The following is a description of a gene set: Mouse Gene Set: TABULA_MURIS_SENIS_LIVER_NK_CELL_AGEING from publication Tabula Muris Consortium (PMID 32669714) studied in species Mus musculus, and this is the list of marker genes: Rpl17, Ptbp3, Neurl3, Rpl22l1, Pafah1b1, Rpl3, Odc1, Rpl27a, Rdx, Akap13, Pkp3, Ccl5, Plekha2, Erdr1, Rps20, Surf1, Gzmb, Ddx21, Slc25a4, Vmp1, Psma2, Cdv3, Taf1d, Fyn, Eif3c, Hspa5, Serpina3g (serine (or cysteine) peptidase inhibitor, clade A, member 3G), Atf4, Dnajb1, Irf2, Use1, Ly6a, Rbm39, Rps28, Prkch, Gpr132, Ahnak, Cst7, H2-Q4, Samsn1, Rpl13a, Uqcrc2, Capg, Stat3, Tox, Ptges3, Cd72, Rps21, Ptp4a2, Rpl38, H2-Q7, Npm1, Camk2n1, Rab8b, Gm6654, Jchain, Ghitm, Sat1, Btg1 (NCBI Gene Id 380657), Gm6222, Slc3a2, Pglyrp1, Kif5b, Fau, Ptprc, Crbn, Ptpn22, Vim, Peli1, Adipor1, H2-Eb1, Pold4, Eef1d (eukaryotic translation elongation factor 1 delta), Pgk1, Swi5, 1810037I17Rik (RIKEN cDNA 1810037I17 gene), Rsrc2, Igbp1, Cct8, Gm9320, Rpsa, Fos, Lgals1, Txn1, Gpbp1, Trmt112, Lgals3, H2-Ab1, Ankrd12, Rps29, Lrrc58, H2-Aa, Sh2d1a, Celf2, Gna13 (guanine nucleotide binding protein, alpha 13), Pmf1 (polyamine-modulated factor 1), Acbd6, Eef2, Rack1, Eif2s2, Ube2i, Oaz1, Klf6, Gng2, Rpl6, Npm3-ps1, Rps18, Rbbp7, Ncl, Rnaset2b, Rps15a-ps4, Hnrnpab, Bhmt, Icam1, Cacybp, Neat1, Ctss, Gas5, Ppp1r15a, Rpl36, Srsf7 (NCBI Gene Id 60426), Comt, Il21r, Kmt2e, Rps13, Ssrp1, Srrm1, Srsf2, Ets1, Rpl30, Lrrfip1, Gm12191, S100a6, Mt1, Ccl4, Acap1, Junb, Rpl34, Hnrnpdl, Rpl12, Zfp622, D8Ertd738e, Hspd1, Glipr2, Rpl31-ps12, Npm3, Emd, Zfp36l1, Khdrbs1, Hsp90aa1, Rbm3, Klf10, Ctsd, Rpl34-ps1, Luc7l2, Cnbp, Tap1, Ifrd1, Hamp, Smad7, Eif3m, Rps15a-ps6, Tmem176a, Pim1, Tmem176b, Klf2, Sh3kbp1, Rps19, Rpl32l, Rgs1, Rbpj, Cish, Hp1bp3, Cd82, Psmb9, Hmgn1, Metrnl, Mrpl52, Fyb1, Hspa4, Ms4a6b, Ctla2a, Nsa2, Smarca5, Tcp1, Sugt1, Tap2, Luc7l3, Gm6402, Dock10, Limd1, Ubb, Rpl24, Atxn2l, Cd8b1, Tpm3, Rsbn1l, Gm15421, Rpl18a, Cd74, Irf1, Actn4, Anp32b, H2-T23, Hnrnpm, Slc38a2, Cox7a2l, Nol7, Mir703, Eif3e, Rpl37, Eif4b, Papola, Iqgap1, Eif3f, S100a4, Cd7, Rps15a, Arpc4, Cct7, Ifi27, Brd2, Dazap1, Emp3, Cct2, Rap1a, Clk1, Naca, Rpl32, Capza2, Runx3, Lime1, Ndufs5-ps, Tmem254, Snhg8, Cd8a, Prkca, Rgs2, Itga4, Ccdc12, 2410006H16Rik, Jun, Adss1, Rpl7a, Bhlhe40, Btg2, Tra2b, Glrx, Tspan13 (NCBI Gene Id 66109), Coro1b, Morf4l1-ps1, Laptm5, Anxa2 (NCBI Gene Id 12306), Ubb-ps, Sh3glb1, H2ax, Grb2, Smc4, Tcf25, Nucks1, Slx1b, Atp5me (ATP synthase membrane subunit e), Bcl2a1b, Zfas1, Rps12, Cdc37, Wbp2, Hspa8, Ptbp1, Rpl39, Rpl14, Tnfaip3, Saraf, Vps37b, Dek, Hsp90ab1, Dnajc9, Tmf1, Stmn1, Eloc (elongin C), Batf, Wdr89, Spn, Fam111a (NCBI Gene Id 68258), H2ac23, Rps5, Tspan15